The following is a description of a gene set: Human Gene Set: GOBP_BLOOD_VESSEL_MORPHOGENESIS The process in which the anatomical structures of blood vessels are generated and organized. The blood vessel is the vasculature carrying blood. species: Homo sapiens, and this is the list of marker genes: ANXA3, OPTC, MMRN2 (NCBI Gene Id 79812), GJC1, LRP2, CYP1B1 (cytochrome P450 family 1 subfamily B member 1), HIPK1, MIA3 (MIA SH3 domain ER export factor 3), BMPR2, TJP1, SPI1, SYK, MYH9, NFATC4, MIR126, ANXA2, MEIS3, TBX20 (NCBI Gene Id 57057), SPARC (NCBI Gene Id 6678), MIR378A, FZD8, MIR145, SOX17, KRIT1, PIK3C2A, ITGAV, MIR503, YJEFN3, EPGN, PRL, MIR1298, MIR27B, STAB2, JAG1, EMP2, ID1, MIR24-1, CSPG4, TGFB1, COL18A1, COL4A2, ABL1, AAMP, WNT7B, CAV1, SFRP1, MIR296, ADGRF5, SMO, RBPJ, HOXB3, AGTR1, ITGB1BP1, PDGFRB, PTGS2, GHRL, SLIT2, SOS1, MIR92A1, MIR361, OVOL2, EMILIN1, DLL1, MEOX2, AKT3, ROCK1, MIR22, EFNA1, CD36, ERAP1, MMRN1, STK4, AIMP1, SLC12A6, PTK2B, SMAD1, CCR3, TNNI3, MIR31, TAL1, COL4A3, SIRT6 (NCBI Gene Id 51548), JMJD8, NUS1, HOXA1, MAP2K5, TMEM201, BSG, BMPR1A, PGK1, NR2E1, EYA1, MIR19B1, PTGIS, ANXA1, STAT3, DAG1, MIR30E, SRF, ANGPTL3, SGPL1, EGR3, WASF2, ASB4, PTK2, LRG1, SPINK5, RBM15, CALCRL, MIR34C, MYO1E, CDH5, MIR16-1, LDLR, GDF2, E2F2, MIR138-1, SCG2, ITGB2, ADAM12, TNN, RSPO3, BMPER, EMILIN2, IL6, MMP2, MIR487B, CHI3L1, HIF1A, TNFAIP3, CYBB, MIR205, TNFRSF12A, C5AR1, SEMA4A, WNT4, MIR26A1, ADAM15, CLIC3, ANG, RRAS, VPS4B, FGFR2 (NCBI Gene Id 2263), PDCD6 (NCBI Gene Id 206269), GPR4 (G protein-coupled receptor 4), ACVRL1, ELK3, SRPX2, PARVA, CEACAM1, MIR20B, VEGFD, MINAR1, CD47, MIR200B, HAND2, COL8A2, MIR206, SOX4, JMJD6, MYO18B, CD34, PF4, FGFBP1, ANPEP, MIRLET7G, LEPR, WT1, MIR15A, MIR222, MAPK14, EPN2, ZNF354C, ANGPT1, EPHB1, UBP1, MIR492, MIR153-1, NF1, HMGA2, DAB2IP (DAB2 interacting protein), TGFA, ADGRG6, ITGB8, FZD4, APOLD1, FLT1, MIR21, STRA6, HSPG2, UNC5B, SLC31A1, MIR193A, ATF2, MIR29C, NDP, FKBPL, ZFP36L1, NKX2-5, ROBO1, RIN2, PPP1R16B, SEMA6A (semaphorin 6A), MIR15B, NR2F2, LRP5, HDAC9, HIPK2, EDN1, TBX4, OR10J5, RUNX1, ZFPM2, MIR199A1, AMOTL1, CNMD, HLA-G, MIR495, HOXA3, CITED1, ADM2, THBS1, THBS2, ARHGAP24, PLCD3, FOXC1, NOX5, C3AR1, MYDGF, HS6ST1, IL12B, AMOTL2, MIR375, ALOX5, TIPARP, WNT11, SMOC2, CTNND1, NRP1, MIR939, SOX18, MIR451A, NR4A1, JAM3 (junctional adhesion molecule 3), PDGFA, JAK1, FGF8, ISL1, ARHGAP22, TIE1, MECP2, CHD7, NPPC, RNF213, FGF10, LEF1, TMEM215, MIR18A, MIR497, TCF21, PRKX, EPHA1, ACTG1, SPRY2 (sprouty RTK signaling antagonist 2), MIR212, FGF1, TGFBR3, EGFL7, GPX1, PRKD1, MEGF8, JCAD, FN1 (NCBI Gene Id 2335), TBX5, CTNNB1, TNFSF12, HSPB1, ENPEP, RTN4, CRIPTO, EDN2, SEMA5A, MIR30C1, NAA15, CLDN5, GREM1, HTN1, HHEX, MIRLET7A1, ATP5F1B, CCR2, EPHB2, F3, CX3CR1, NRXN1, CD160, PLCG1, ADTRP, RAMP1, HAND1, RECK, PKD2, MED1, TLR3, THY1, GRN, EHD4, VEGFB, CCDC134, STIM1, ECM1, VASH1, NAGLU, TNMD, CCL11, CXCL17, ACVR1, EPN1, SP1, FLT4, NRP2, MIR214, CCL2, CIB1, EPHB3 (EPH receptor B3), MIR130A, CASP8, FOXJ2, HEY1, TGFBI, ERBB2, STARD13, PRKD2, GAB1, AGO2, GBX2, SEC24B, NPR1, MIR125B1, HTATIP2, PIK3CA, SAT1, JUP, MEIS3P1, CX3CL1, NRXN3, RHOJ, CXCL13, ITGA5, FKBP10, CD93, GADD45A, STAT1, MIR640, GLUL, KLF4, AGGF1, SULF1, MIR210 (microRNA 210), ADAMTS9, PPP3R1, MIR221, ITGA2B, WARS1, PRDM1, ADGRA2, MIR17, SFRP2, HGS, ARID2, TYMP, PIK3R6, PTPRJ, ACKR3, GTF2I, MIR217, PROK2, NOTCH1, SIRT1, BCAM, PROK1, IGFBP7, ADGRB2, MIR125A, RAPGEF2, B4GALT1 (NCBI Gene Id 2683), IL10, LRP1, BRCA1, PXDN, ETV2 (NCBI Gene Id 339321), HSPB6, TGFB2, ETS1, JUN, LEP, RAP1A, HIF1AN, NGFR, GATA6, C1GALT1, STAB1, PECAM1, ESM1, PDCD10, GPR15, CCN1, ROBO4, TWIST1, HOXA5, MIR494 (NCBI Gene Id 574452), BMP4, EFNB2, FMNL3, MIR410, MICALL1, TEAD2, MAPK7 (NCBI Gene Id 5598), SLC1A1, EMC10, NFATC3, PDGFB, TERT, BAX, WNK1, HEY2, MDK, ATP5IF1, MMP14, SASH1, LOX, PAK4, CUL7, DDAH1, MIR29A, TNFAIP2, CARD10, NPR2, CDH13, MIR34A, AMOT, FGF18, HOXA13, ZMIZ1, HYAL1, HOXA7, TBXA2R, TMEM100, MIR424, ANGPTL4, E2F7, ABCC8, PDPK1, PKM, RASA1, PIK3R3, SLC12A2, TBX2, FAP, FOXN1, APOD, RNH1, PRKCA, KLF5, HPSE, NINJ1, VAV2, MIR29B1, EFEMP2, APOE, E2F8, IL12A, EGLN1, VEGFC, PANK2, MIR10A, QKI, ECSCR, TEK, HSPA12B, ITGB1, CITED2, THBS4, HK2, GLMN, TGM2, MIRLET7B, CXCL8, MFGE8, MIR329-1, SHH, MIR99B, MIR27A, NOTCH2, HPGD, NAXE, MIR199B, NTRK1, APLN, SPRED1, NFE2L2, NOG, MIR483, PGF, EFNA3, ADAM8, MIR20A, PKNOX1, FYN, FZD5, EDNRA, DCN, EIF2AK3, GNA13, RAMP2, ANGPTL6, PTPRB, PITX2, MIR200C, LAMA1, NPPB, CLEC14A, CCL24, DLL4 (delta like canonical Notch ligand 4), FOXC2, EPHB4, SHB, NCL, MIR150, MIR30B, APELA, CCM2, SERPINE1, KRT1, COL4A1, MIR10B, XBP1, CREB3L1, SERPINF1, CCN2, MIR19A, SERPINF2, MYOCD, PML (PML nuclear body scaffold), ADGRG1, MYLK, SRPK2, PDE3B, GATA4, MIR1908, FUT1, MEIS1, APOB, NOX1, COL8A1, HAS2, COMP, MCAM, APOH, EGFL8, GPLD1, NODAL, KDR, NPR3, SEMA3E, MIR137, PPARG, PDGFRA, MIR2355, MIR181B1, VAV3, ENG, APLNR, SMAD7, ADM, HOXB13 (NCBI Gene Id 10481), PIK3CB, MIR23A, BCAS3, NEDD4, TSPAN12, TAFA5, PRKCB, COL15A1, AQP1, SHC1, MIR320A, FOXO4, WARS2, IL17F, ITGB3, ATP2B4, S1PR1, ADIPOR2, GATA2, NRCAM, RGCC, KLK3, YWHAZ, EREG, GPNMB, MIRLET7F1, S100A7, VASH2, PRRX1, PIK3CG, RHOB, RAPGEF3, NOTCH3, CLIC4, GHSR, MIR185, ADGRB1, EGF, CDH2, RELA, MIR106B, RORA, CD40, ADGRB3, PIK3CD, NDNF, HDAC7, TBX1, WNT5A, VEZF1, MIR101-1, PLXDC1, LOXL2, HES1, YAP1, MIR30A, HMGB1, MIR342, AKT1, MIR505, MIR1-1, NTRK2, JUNB, CHRNA7, PLK2, MIR885, ANGPT2, SP100, ADAMTS1, FOLR1, MMP19, TSPAN18, MIR34B, FBLN5, WNT7A, PTPRM, SARS1, POFUT1, SPHK1, EPHA2, OTULIN, MIR1224, VSTM4, TMIGD2, ITGAX, PROX1, RHOA, HEG1, MIR377, COL3A1, BAK1, ZNF304, FGF6, MIR132, NRARP, FGF9, TGFBR1, MIR146A, FGF2, FGF16, MIR143, HRG, ROCK2, NPRL3, FOXF1, SYNJ2BP, ANGPT4, CELA1, THSD7A, VEGFA, TNF, PTPN6, FGFR1, KLF2, CXCL10, DSG2, ZC3H12A, TGFBR2, RLN2, MINAR2, CMA1, AGO1, MTDH, NOS3, SIX1, NOTCH4, IHH, TFAP2B, HIF3A, IL18, GJA5, CXCR3, CCN6, PDCL3, CCN3, CAMP, MIR196A1, PRCP, SGCD, CCBE1, CEMIP2, ISM1, FASLG, C3, PACSIN2, PLXND1, PAXIP1, BTG1, MIR149, S100A1, IL1B, FOXH1, HDAC5, HMOX1, SH2D2A (SH2 domain containing 2A), IL1A, EPAS1 (endothelial PAS domain protein 1), RASIP1